The following is a description of a gene set: The 'TEB profile genes': up-regulated during pubertal mammary gland development specifically in the TEB (terminal end bud) structures. from publication McBryan J, Howlin J, Kenny PA, Shioda T, Martin F (PMID 17486082) species: Mus musculus Mouse Gene Set: MCBRYAN_TERMINAL_END_BUD_UP Expression microarray analysis identified over genes regulated during puberty in the mouse mammary gland. Most prominent were genes whose expression increased in parallel with pubertal development and remained high thereafter. Members of the Wnt, transforming growth factor-beta and oestrogen-signalling pathways were significantly overrepresented. Comparison to expression data from CITED1 knockout mice identified a subset of oestrogen-responsive genes displaying altered expression in the absence of CITED1. Included in this subset are stanniocalcin2 (Stc2) and amphiregulin (Areg). Chromatin immunoprecipitation revealed that ERalpha binds to oestrogen response elements in both the Stc2 and Areg genes in the mammary gland during puberty. Additionally, CITED1 and ERalpha localize to the same epithelial cells of the pubertal mammary gland, supporting a role for interaction of these two proteins during normal development. In a human breast cancer data set, expression of Stc2, Areg and CITED1 parallel that of ERalpha. Similar to ERalpha, CITED1 expression correlates with good outcome in breast cancer, implying that potential maintenance of the ERalpha-CITED1 co-regulated signalling pathway in breast tumours can indicate good prognosis., and this is the list of marker genes: Igfbp2, Myh11, Sfrp1, Ehf, Mup1, Sdc1, Gsta3, Egr2, Ly6d, Rnf149, Tnfrsf12a, Tns1, Cnn1, Cdk1